The following is a description of a gene set: Formation of the Early Elongation Complex studied in species Homo sapiens Human Gene Set: REACTOME_FORMATION_OF_THE_EARLY_ELONGATION_COMPLEX, and this is the list of marker genes: POLR2A, ERCC2, GTF2H5, POLR2E, CDK7, NELFCD, MNAT1, NELFE, GTF2H1, POLR2L, GTF2F1, POLR2G, GTF2F2, GTF2H3, CTDP1, SUPT5H, POLR2H, GTF2H4, POLR2F, ERCC3, POLR2J, NCBP1, POLR2I, POLR2D, SUPT4H1 (NCBI Gene Id 6827), NELFB, NCBP2, NELFA, POLR2C, CCNH, GTF2H2, POLR2K, POLR2B